Given this list of marker genes SLC2A3, AKR1C3, CXCL14, GCLC, ST13, THBS1, GPNMB, UGT1A6, DKK3, CALU, ALCAM, HOXD8, here is a description of the gene set: from publication Ito T, Shimada Y, Kan T, David S, Cheng Y, Mori Y, Agarwal R, Paun B, Jin Z, Olaru A, Hamilton JP, Yang J, Abraham JM, Meltzer SJ, Sato F (PMID 18451147) Genes up-regulated in HSA/c and KYSE140 cells (esophageal squamous cell carcinoma, ESCC) after knockdown of PTTG1 by RNAi. Human Gene Set: ITO_PTTG1_TARGETS_UP Human pituitary tumor-transforming 1 (PTTG1)/securin is a putative oncoprotein that is overexpressed in various tumor types. However, the involvement of PTTG1 in gastrointestinal cancer development and progression remains unclear. In this study, we investigated the clinical significance and biological effects of PTTG1 in esophageal squamous cell carcinoma (ESCC). Immunohistochemical studies performed on 113 primary ESCC specimens revealed a high prevalence of PTTG1 overexpression (60.2%), which was significantly associated with lymph node metastasis (regional, P = 0.042; distant, P = 0.005), advanced tumor stage (P = 0.028), and poorer overall survival (P = 0.017, log-rank test; P = 0.044, Cox proportional hazard model). Eleven ESCC cell lines expressed PTTG1 protein at levels 2.4 to 6.6 times higher than those in normal esophageal epithelial cells (HEEpiC). PTTG1 protein expression was confined to the nucleus in HEEpiC cells but present in both the cytoplasm and nucleus in ESCC cells. Two small interfering RNAs (siRNA) inhibited PTTG1 mRNA and protein expression in three ESCC cell lines by 77% to 97%. In addition, PTTG1 down-regulation by these siRNAs significantly reduced cell motility in all three ESCC cell lines (P < 0.01) in vitro, as well as popliteal lymph node metastases of ESCC cells in nude mice (P = 0.020). Global gene expression profiling suggested that several members of the Ras and Rho gene families, including RRAS, RHOG, ARHGAP1, and ARHGADIA, represented potential downstream genes in the PTTG1 pathway. Taken together, these findings suggest that PTTG1 overexpression promotes cell motility and lymph node metastasis in ESCC patients, leading to poorer survival. Thus, PTTG1 constitutes a potential biomarker and therapeutic target in ESCCs with lymph node metastases. species: Homo sapiens